Given this list of marker genes SLC35C1, SLCO4C1, SLC29A4, SLCO2A1, SLC29A1 (NCBI Gene Id 220811), SLCO2B1, SLCO1B3, LCN15, AVP, SLC27A4, SLC25A4 (solute carrier family 25 member 4), SLCO3A1, SLC35A2, LCN12, LCN1 (lipocalin 1), SLC28A1, SLC27A6, PDZD11, ARL2 (NCBI Gene Id 402), SLC25A6, SLC5A6, SLC35B2, SLC28A2, SLCO1A2, SLC35A3, SLC35A1, SLC29A3, SLCO4A1, SLCO1B1, SLC35D2 (solute carrier family 35 member D2), SLCO1C1, SLC35B4, APOD, SLC28A3, SLC33A1, SLC35B3, SLC29A2, SLC25A5, LCN9, SLC16A2, ARL2BP, SLC27A1, SLC35D1, here is a description of the gene set: studied in species Homo sapiens Transport of vitamins, nucleosides, and related molecules Human Gene Set: REACTOME_TRANSPORT_OF_VITAMINS_NUCLEOSIDES_AND_RELATED_MOLECULES